Given this list of marker genes Dgcr8, Bcdin3d, Ago3, Tut7, Tut4, Pum1, Zc3h7b, Bmp4, Srrt, Ago2, Trim71, Ripk1, Mecp2, Mir361, Ncbp1, Trp53, Adar, Hnf1a, Zc3h7a, Trub1 (NCBI Gene Id 98137), Il6, Stat3, Prkra, Drosha, Snip1, Ago4 (argonaute RISC catalytic subunit 4), Pus10, Mettl3, Lin28a, ENSMUSG00000126352, Ago1, Hnrnpa2b1, Dicer1, Pum2, Zc3h10, Lin28b, Nup155, Tarbp2, Ncbp2, Tgfb1, Ddx5, Ddx3x, Srsf3, Spout1, Zmpste24, Rbm3, here is a description of the gene set: Mouse Gene Set: GOBP_MIRNA_PROCESSING A process leading to the generation of a functional miRNA. Includes the cleavage of stem-loop RNA precursors into microRNAs (miRNAs). miRNAs are a class of small RNAs that primarily silence genes by blocking the translation of mRNA transcripts into protein, or by increasing the degradation of non-protein-coding RNA transcripts. species: Mus musculus